Given this list of marker genes Asph, Osbpl8, Emd, Arv1, Stimate, Stim1, C2cd2l, Tmem201, here is a description of the gene set: Mouse Gene Set: GOCC_CORTICAL_ENDOPLASMIC_RETICULUM A cortical network of highly dynamic tubules that are juxtaposed to the plasma membrane and undergo ring closure and tubule-branching movements. species: Mus musculus